Given this list of marker genes GANAB, AGPAT4, APP, SATB2, SPACA6, MAX, here is a description of the gene set: studied in species Homo sapiens Genes having at least one occurence of the motif TCGATGG in their 3' untranslated region. The motif represents putative target (that is, seed match) of human mature miRNA hsa-miR-213 (v7.1 miRBase). Human Gene Set: TCGATGG_MIR213